Given this list of marker genes Hoga1, Mboat2, Slc7a11, Duoxa1, Vnn1, Mthfsl, Pla2g10, P4ha2, Sod2, Idh1 (NCBI Gene Id 98427), Bbox1 (gamma-butyrobetaine hydroxylase 1), Lpcat4, Vnn3, Abcc1, Foxe1, Lipc, Eif2ak3, Crat, Gsta2, Mboat1, Cpt1c, Gstt2, Gstm7, Bhmt1b, Mtr, Chac1, Mtrr, Sult1b1, Sult2a6, Ero1b, Gsta13, Gsr, Nfe2l2, Tpo, Aasdhppt, Gsta4, Mthfd1l, Kcnj6, Acadl, Gamt, Reln, Gstm2, Pla2g3, Gstt4, Pax8, Gcnt4, P4hb, Pla2g2f, Gatm, Plod2, Shmt1, Gstt1, Slc26a7, Gstm1, Slc27a1, Dio1, Ctsb, Dio2, Ctns, Gstp-ps, Ctsk, Mthfd1, Gart, Mfsd2a, Ckm, Park7, Ptdss1, Crtap, Gstm6, Prdx4, Gstm5, Ctsl, Ggact, Gstp1, Sardh, Med1 (mediator complex subunit 1), Crym, Mthfr, Gsta3, Gata3, Slc22a4, Crot, Sult2a3, Slc1a2, Ggh, Folh1, Hpgds, Ggt7, Dhfr, Pemt, Ndp, Cpt2, Gss, Gsta5, Pcyox1, Shmt2, Txnrd3, Aldh1l1, Slco1c1, Atic, Pcyox1l, Cth, Acadm (acyl-Coenzyme A dehydrogenase, medium chain), Gpx1, Gstz1, Icmt (isoprenylcysteine carboxyl methyltransferase), Gstp3, Tg, Mthfd2, Bhmt2 (NCBI Gene Id 97887), Folr1 (folate receptor alpha), Abhd12b, Gstm3, Ckmt1, Cryaa, Chac2, Cpq, Egln2, Bhmt, Pm20d2, Cpt1b, G6pdx, Aldh7a1, Iyd, Gclc, Ethe1, Pla2g15, Mthfs, Aldh9a1, Chdh, Lpcat3, Mthfd2l, Gstk1, Ftcd (NCBI Gene Id 14317), Sod1, Aldh1l2, Ahcy, Plscr1, Cpt1a, Gsto2, Slc16a10, Fkrp, Abhd16a, G6pd2, Plod3, Mgst1, Serinc2 (serine incorporator 2), Mgst2 (NCBI Gene Id 211666), Serinc5 (NCBI Gene Id 97832), Oplah, Gch1, Hpn, Slc46a1, Ckmt2, Abhd12, Sult2a5, Sult1a1, Ggt5, Abcc2 (NCBI Gene Id 12780), Ggt1, Mmachc, Hmgn5 (high-mobility group nucleosome binding domain 5), Sult2a2, Nox1, Agxt2, Sult2a1, Nat8, Slc1a1, Dio3, P4ha1, Sult2a8, Duox2, Sult2a7, Slco4a1 (NCBI Gene Id 28251), Gstm4 (NCBI Gene Id 68555), Slc22a5, Ahcyl, Dpep1, Ptdss2, Duoxa2, Serinc1, Abhd16b, Pcmt1, Gsta1, Nfe2l1, Ggt6, Slc5a5, Hagh, Ass1, Fpgs, Aaas, Gclm, Ero1a, Ckb, Arl6ip5, Slc16a2, Gnmt, Dmgdh, Gsto1, Cga, Asl, Gstp2, Sult2a4, Gstt3, Glo1, Tyms, Cryab, here is a description of the gene set: Mouse Gene Set: GOBP_MODIFIED_AMINO_ACID_METABOLIC_PROCESS The chemical reactions and pathways involving compounds derived from amino acids, organic acids containing one or more amino substituents. species: Mus musculus